The following is a description of a gene set: Skeletal dysplasia A general term describing features characterized by abnormal development of bones and connective tissues. species: Homo sapiens Human Gene Set: HP_SKELETAL_DYSPLASIA, and this is the list of marker genes: PEX13, GPX4, DNAJC21 (NCBI Gene Id 134218), TONSL, POLE, KANSL1, NEU1, PEX5, COL9A1, AIFM1, COL11A2, COL9A3, HESX1, PEX10, SMO, MAP3K7, NDNF, P4HB, CTSA, RUNX2, STAC3, DYNC2I2, HDAC6, VPS33A, HS6ST1, EXOC6B, ACTG1 (NCBI Gene Id 71), FGF17, PEX16, POLR1C, PEX1, CCN6 (NCBI Gene Id 8838), PHYH, PAPSS2, HSPG2, DYM, FLNB, SOX10 (NCBI Gene Id 8223), EXTL3 (exostosin like glycosyltransferase 3), ANKH, LRRK1, EIF2AK3, SEC23A, HSPA9, SMARCAL1 (SWI/SNF related, matrix associated, actin dependent regulator of chromatin, subfamily a like 1), CHD7, NPR2, DYNC2I1, TRAPPC2 (trafficking protein particle complex subunit 2), CDKN1C, EFL1, RNU4ATAC, DYNC2H1, PROK2, CEP120 (NCBI Gene Id 153241), GLI3, KRAS, ALDH3A2, CCDC141, PEX7, WDR19, SFRP4, GLB1, RMRP, PEX2, ACP5, PERCC1, TRIP11, B4GALT7, COL2A1, IFT140, IARS2, SLC39A13, WDR11, RPL10, COL10A1, XYLT1, SPRY4, DMP1, KIAA0753, KIF22, DPYD, ABCC9, DUSP6, IDUA, WDR35, PTEN, PEX11B, ACTB, UFSP2, MMP13, CDH3, GNS, TCOF1, DYNC2LI1, FGFR3 (NCBI Gene Id 55546), PEX6, MBTPS1, AKT1, COL11A1, GJA1, EPCAM, ARSB, SF3B4, BMPR1B, KCNJ8, IFT80, ANOS1, COMP, NOTCH2, PEX26, ALG6, SPRED1, RECQL4, BMP4 (bone morphogenetic protein 4), NKX3-2, POP1, SEMA3A, PTH1R, CWC27, PEX14, TRPV4, NF1, LIFR, PIK3C2A, TTC21B, DDR2, FLNA, CFAP410, TYROBP, LTBP3, GNAS, FGF8, IFT172, POLR1D, RSPRY1, FGFR1, TREM2, COL9A2, SEC24D (NCBI Gene Id 9871), KIF7, CHST3, PCYT1A, IHH, TMEM53, POLR1B, ACAN, NMNAT1, ALG3, FLRT3, NANS, CRTAP, NLRP3, MATN3, TACR3, BGN, PEX3, LBR, B3GALT6, TBXAS1, FN1, ENPP1, SRP54, GEMIN4, TMEM165, CANT1, SBDS, ALG9, ANAPC1, PAM16, COL3A1, DCC, DCHS1, TMEM67, PEX12, LONP1, GDF5, FEZF1, SLC26A2, IL17RD, DDRGK1, PEX19, PROKR2, TGFB1, IDH1, FAT4